Given this list of marker genes FRRS1L, SRPX2, GABRG2, GRIN2A, IQSEC2, here is a description of the gene set: studied in species Homo sapiens EEG with centrotemporal epileptiform discharges Human Gene Set: HP_EEG_WITH_CENTROTEMPORAL_EPILEPTIFORM_DISCHARGES Focal epileptiform EEG discharges recorded in the centrotemporal region.